Given this list of marker genes Gdf9, Mfn2, Retn, Zfpm2, Nupr1, Insr, Runx1, Wt1, Nr5a1, here is a description of the gene set: species: Mus musculus Mouse Gene Set: GOBP_REGULATION_OF_FEMALE_GONAD_DEVELOPMENT Any process that modulates the frequency, rate or extent of female gonad development.